Given this list of marker genes Tep1, Syndig1l, Epsti1, Cox7a2l, Erp29, Pycard, Aif1, Chchd10, Apoe, Tifab, Irf8, Ptpn18, Enpp1, Calm2, Ndufa6, Ly6e, Vamp5, Atp13a2, Comt, Lamtor4, Abhd17a, Tmem86a, Siglech, Arhgef10, Hpgd, Ppfia4, Cmah, Rgs2, Npc2 (NPC intracellular cholesterol transporter 2), Fam43a, Gdi2, Uchl3, St6galnac4, Klf2, Tmem160, Ncoa4, Creg1, Ubb, Atp5mc2, Mrpl42, Rgs10, Ypel3, Myl12b, Cox4i2, Mtss1, Ighm, here is a description of the gene set: from publication Cui A, Huang T, Li S, Ma A, Pérez JL, Sander C, Keskin DB, Wu CJ, Fraenkel E, Hacohen N (PMID 38057668) studied in species Mus musculus Cytokines mediate cell-cell communication in the immune system and represent important therapeutic targets. A myriad of studies have highlighted their central role in immune function, yet we lack a global view of the cellular responses of each immune cell type to each cytokine. To address this gap, the authors created the Immune Dictionary, a compendium of single-cell transcriptomic profiles of more than 17 immune cell types in response to each of 86 cytokines (>1,400 cytokine-cell type combinations) in mouse lymph nodes in vivo. A cytokine-centric view of the dictionary revealed that most cytokines induce highly cell-type-specific responses. For example, the inflammatory cytokine interleukin-1β induces distinct gene programmes in almost every cell type. A cell-type-centric view of the dictionary identified more than 66 cytokine-driven cellular polarization states across immune cell types, including previously uncharacterized states such as an interleukin-18-induced polyfunctional natural killer cell state. Genes negatively differentially expressed in cell type: Macrophage upon treatment with cytokine: TNF-α in mouse lymph nodes in vivo. Mouse Gene Set: CUI_MACROPHAGE_TNFA_RESPONSE_DN